Given this list of marker genes Fos, Klf2, Dusp1, Btg2, Atf3, Jund, Pmaip1, Junb, here is a description of the gene set: Genes negatively differentially expressed in cell type: cDC1 (conventional dendritic cell type 1) upon treatment with cytokine: CD30L in mouse lymph nodes in vivo. studied in species Mus musculus Mouse Gene Set: CUI_CDC1_CD30L_RESPONSE_DN Cytokines mediate cell-cell communication in the immune system and represent important therapeutic targets. A myriad of studies have highlighted their central role in immune function, yet we lack a global view of the cellular responses of each immune cell type to each cytokine. To address this gap, the authors created the Immune Dictionary, a compendium of single-cell transcriptomic profiles of more than 17 immune cell types in response to each of 86 cytokines (>1,400 cytokine-cell type combinations) in mouse lymph nodes in vivo. A cytokine-centric view of the dictionary revealed that most cytokines induce highly cell-type-specific responses. For example, the inflammatory cytokine interleukin-1β induces distinct gene programmes in almost every cell type. A cell-type-centric view of the dictionary identified more than 66 cytokine-driven cellular polarization states across immune cell types, including previously uncharacterized states such as an interleukin-18-induced polyfunctional natural killer cell state. from publication Cui A, Huang T, Li S, Ma A, Pérez JL, Sander C, Keskin DB, Wu CJ, Fraenkel E, Hacohen N (PMID 38057668)